The following is a description of a gene set: species: Homo sapiens Oxidative Stress Induced Senescence Human Gene Set: REACTOME_OXIDATIVE_STRESS_INDUCED_SENESCENCE, and this is the list of marker genes: EED, BMI1, H2BC26, TXN, CBX2, MDM2, PHC3, H3C4, H3C2, CDK4, UBC, TFDP2, TP53, H3-3A, H4C9, AGO3, UBB, TNRC6A, PHC2, MAPKAPK5, H2BC7, TNIK, H2BC13, PHC1, H2BC21, H2AC4, H3C10, KDM6B, MAPK8, AGO4 (NCBI Gene Id 54791), MAPK11, MAPK3, H3C8, H2BC5, H4C15, JUN, H2BC14, EZH2, E2F1, H3C3, TFDP1, H2BC10, CBX8, CDKN2C, FOS, SUZ12, MAPK1, H2BC17 (NCBI Gene Id 8348), CBX6, CDKN2D, MAPK9, CDKN2A, MOV10, H4C12, SCMH1, TNRC6C, CBX4, H2BC12, H2BC1, MAP3K5, H2AX, H3C1, MAPK14, H3C14, H2AC14 (H2A clustered histone 14), H2AC6, AGO1, H4C1, H4C5, H3C15, H2AC20, MINK1, H4C8, H2AJ, MAP2K6, H2BC12L, MIR24-1, H3C12, TNRC6B, H4C13, RNF2 (ring finger protein 2), H4C2, H2BC11, H4C4, H3C11, H2BC8, RBBP4, MIR24-2, H2BC3, E2F3, E2F2, MAP2K3, H2AC8 (NCBI Gene Id 3012), H4C14, H3C13, H3C7, UBA52, H4C3, H2BC15, RBBP7, H3C6, H3-3B, H2AB1, H2AZ2, MAPKAPK3, H4C16, MAP2K4, CDKN2B, MAP4K4, CDK6, H2BC6, H4C11, H2BC9, H2AC19, MAPKAPK2, H2AC18, MDM4, IFNB1, MAP2K7, RING1, MAPK10, H4C6, RPS27A, H2AC7, H2BC4